Given this list of marker genes Pip4p1, Pip4k2c, here is a description of the gene set: part of: PI Metabolism This event has been computationally inferred from an event that has been demonstrated in another species.<p>The inference is based on the homology mapping from PANTHER. Briefly, reactions for which all involved PhysicalEntities (in input, output and catalyst) have a mapped orthologue/paralogue (for complexes at least 75% of components must have a mapping) are inferred to the other species. electronically inferred by orthology from the curated human pathway species: Mus musculus Reactome Pathway: Synthesis of PIPs in the nucleus